Given this list of marker genes NKX2-5, MIR145, MYOCD, MDK, NFE2L2, PAX8, NOTCH1, MIR106B, MIR133A1, NOL3, ATG5, SFRP2, MIR30E, HEY2, SIRT5, PPP1R10 (NCBI Gene Id 5514), MIR19A, MIR199A1, MIR20A, MIR21, HSPB6, BMP7, JAK2 (NCBI Gene Id 3717), MIR24-1, NACA, CFLAR, HSF1, MIR19B1, NUPR1, HAND2, GATA4, RGL2, AMBRA1, NRG1, PDPK1, SIRT4, KIFAP3, BAG3, here is a description of the gene set: Human Gene Set: GOBP_NEGATIVE_REGULATION_OF_STRIATED_MUSCLE_CELL_APOPTOTIC_PROCESS Any process that decreases the rate or extent of striated muscle cell apoptotic process, a form of programmed cell death induced by external or internal signals that trigger the activity of proteolytic caspases whose actions dismantle a striated muscle cell and result in its death. studied in species Homo sapiens